Given this list of marker genes ATL1, SNCA, WASHC5, NR4A2, MT-TT, SNCAIP, PTH, EIF4G1, TBP, ADH1C, MAPT (microtubule associated protein tau), BCKDHA, PMP22, MPZ, SPAST, ADORA2A, NIPA1, SMC1A, CACNA1A, GBA1, ATXN3, ATXN8OS, OPA1, ATXN2, here is a description of the gene set: Human Gene Set: HP_TEMPORAL_PATTERN Temporal pattern studied in species Homo sapiens The speed at which disease manifestations appear and develop.